The following is a description of a gene set: Mouse Gene Set: DESCARTES_ORGANOGENESIS_RADIAL_GLIA Mouse Organogenesis Cell Atlas (MOCA) DE_gene_main_cluster.csv, fold.change>=1.5, qval<0.05, pval<0.05 species: Mus musculus from publication Cao J, Spielmann M, Qiu X, Huang X, Ibrahim DM, Hill AJ, Zhang F, Mundlos S, Christiansen L, Steemers FJ, Trapnell C, Shendure J (PMID 30787437), and this is the list of marker genes: 9430041J12Rik, C030037D09Rik, Pdpn (NCBI Gene Id 14726), Slc6a11, Gm30731, Msx3, Hoxc4, Adcy8, Plce1, Cxcr4, Hepacam, Plet1os, Cfap100, Phyhipl, Grid2, Aifm2, Arl4a, Nppc, A230087F16Rik, Slc25a18, Pth2r, Pax3 (NCBI Gene Id 18505), Pla2g7, Cspg5